The following is a description of a gene set: Tolerance induction directed at self antigens. species: Homo sapiens Human Gene Set: GOBP_TOLERANCE_INDUCTION_TO_SELF_ANTIGEN, and this is the list of marker genes: FOXP3, AIRE, TGFB1, LYN, TGFBR2, XKR8